The following is a description of a gene set: studied in species Mus musculus HDR through MMEJ (alt-NHEJ) Mouse Gene Set: REACTOME_HDR_THROUGH_MMEJ_ALT_NHEJ, and this is the list of marker genes: Rbbp8, Parp2 (NCBI Gene Id 30876), Mre11a (NCBI Gene Id 17535), Polq, Xrcc1, Fen1, Lig3, Rad52 (NCBI Gene Id 19365), Rad50, Parp1, Nbn, Brca2